Given this list of marker genes SLC7A11, SYT4, MT3, KCNJ10, PINK1 (PTEN induced kinase 1), ADCY10, CLCN2, ADGRG1, SLC17A8, GFAP, AQP4, HEPACAM, EIF2S1 (NCBI Gene Id 1965), ATP1B2 (NCBI Gene Id 482), GRM5, KCNK2, GRM3 (glutamate metabotropic receptor 3), SLC1A2, APP, SLC2A13, MLC1, GRM2, here is a description of the gene set: Human Gene Set: GOCC_ASTROCYTE_PROJECTION A prolongation or process extending from the soma of an astrocyte and wrapping around neurons. studied in species Homo sapiens